The following is a description of a gene set: Any process that modulates the frequency, rate or extent of nuclear-transcribed mRNA catabolic process, nonsense-mediated decay. Mouse Gene Set: GOBP_REGULATION_OF_NUCLEAR_TRANSCRIBED_MRNA_CATABOLIC_PROCESS_NONSENSE_MEDIATED_DECAY studied in species Mus musculus, and this is the list of marker genes: A1cf, Eif4a3l1, Magoh, Casc3 (NCBI Gene Id 192160), Eif4a3, Nbas, Pabpc1, Apobec1, Eif4a3l2, Hnrnpab, Dhx34, Upf3a, Rbm8a2, Rbm8a, Secisbp2, Magohb, Syncrip